Given this list of marker genes STAG2, NPR2, NONO, NXN, KAT6B, BPTF, IFT74, EIF4A3, IHH, FAM149B1, ERI1, ATP6V1B2, BRAT1, KCNJ11, BBS1, FLT4, AMMECR1, LZTFL1, YY1AP1, JAG1, RSPRY1, FANCM, VPS13B, PLXND1, KMT2A, PRDM16, MYCN, DLK1, TRRAP (NCBI Gene Id 8295), NEDD4L, ORC6, FLNB, TWIST1, MYL11, CREBBP (NCBI Gene Id 1387), CNOT3, FGF16, DLX3, ALDH1A2, HMGA2, ALG12, AKT1, LTBP1, TRIP13, BMP2, KLF13, SLC26A2, ERF, RFWD3, OBSL1, MCTP2, AGO2, ADNP, BMPR1B, RAB11B, CHRNA7, UBE3B, TMEM216, SEMA3E, ACVR1, MAD2L2, TBX4, FLII, PALB2, XRCC4, PTPN11, IFT172 (intraflagellar transport 172), TRAIP, CHSY1, H3-3B (NCBI Gene Id 3021), ATR (ATR serine/threonine kinase), ODC1, B3GLCT, AMER1, SHOX, CDKN1C, TCF20, SCAPER, MAPRE2, DHPS, EIF4A2, WNT5A, COG5, DVL1, ZFPM2, SHANK3, MACROH2A1, RBBP8, COL11A1, XYLT1, TWIST2, EVC, GJA8, DVL3, STAG1, FANCI, COG8, ATRX, RUNX2, HDAC8, PUF60, LEMD3, L1CAM, UBE3A, RAD51, CANT1, SNRPB, SPOP, CSGALNACT1, BUD23, POLA1, NCF1, REV3L, GABRD, WDPCP, POLR1A, SPECC1L, NSUN2 (NOP2/Sun RNA methyltransferase 2), GABBR1, PNPLA6, WDR4, RNF216 (NCBI Gene Id 54476), TMEM147, CDC45, RPL10, CITED2 (Cbp/p300 interacting transactivator with Glu/Asp rich carboxy-terminal domain 2), DNAJC30 (NCBI Gene Id 84277), SOS1, METTL27, BRCA2, FOXP2, SOX6, BBS7, TRIM32, STX1A, GJA1 (NCBI Gene Id 7953), WIPI2, TRAPPC9, RFC2, DDX59, TGDS, EFNB1, SLC2A10, USP7, SIAH1, GTF2IRD2, ADAMTS15, TPR (NCBI Gene Id 7175), PDPN, PITX1, IGF2, GMNN (NCBI Gene Id 51053), SH3PXD2B, BRD4, GATA4, MAF, BRAF, TBX1, HNRNPR, SMARCA2, SMC3, H19, RERE, ERCC4, RB1, ABCC8, RAF1, IFT52, IGF1, HDAC4, UBE4B, RASA2, CDH11, SDCCAG8, XRCC2, LIMK1, UBA2, HEATR3, CUL7, DEAF1, PIGL, MEG3, SALL1, TFAP2B, FANCC, GPC3, FZD2, TBX15, CKAP2L, HSPG2, GATA5, TBX5, CCNK, HOXA11, CHD6, PIGS, PRKCZ, SATB2, GTF2I (general transcription factor IIi), OGT, DNA2, ZC4H2, TTC8, ORC1, BBS12, BBIP1, HOXD13, ARID1B, PHIP, CCDC32, SOX4, GDF1, WDR26, KIFBP, ATRIP, JUP, PIGN, RTL1, BAZ1B, PTH1R, PLAG1, HIC1, BBS9, SIN3A, LMX1B, FANCA, FGD1, BBS5, KRAS, KDM1A, PLK4, CCDC47, QRICH1, TRPM3, NUP85, MECOM, MIA3, TMEM231, KMT2B, PCNT, CHD8, NSD2, SPEN, LUZP1, BRF1 (BRF1 RNA polymerase III transcription initiation factor subunit), GJA5, KDM6B, KDM4B, ATG7, AHDC1, CCDC8, FANCF, IFT140, MRAS, MAP1B (NCBI Gene Id 4131), IFT27, SMOC1, TOPORS, BHLHA9, TCTN3, NKX2-5, MAPK1, DPF2, MAPK8IP3, BBS10, LIG4, CEP57, CBL, FANCD2, DACT1, ORC4, NPHP1, TRIO, NEXMIF, EP300, RBM8A, RAI1, KAT8, EHMT1, SMAD4, NARS2, ELN, MASP1, GATA6, CUL4B, HNRNPH1, FKBP6, TRPS1, GDF5 (growth differentiation factor 5), MKS1, TAF4, PDE6D, SCLT1, TMEM270, CSNK2A1, BUB1B, FGFR3, HOXA13, CEP290, RRAS, PIGH, PIEZO2, BUB3, ZMYM2, EIF4H, CDT1, AUTS2, BRIP1, KDR, CDC6 (NCBI Gene Id 990), VPS37D, MEGF8, PRR12, KCNJ2, DPAGT1, ROR2, ARL6, FRA10AC1, UBR1 (ubiquitin protein ligase E3 component n-recognin 1), CEP152, KMT2D, CASZ1, DSP, OFD1, PACS2, EBF3, GNB2 (NCBI Gene Id 96628), NAA10, ALX1, HNRNPK, NKX2-6, DYM, KCNAB2, NRAS, CHD7, NEK1, TCF4, TBL2, RAD51C, MED12, H4C3, RAD21, KDM6A, GPC4, IFT122, IRX5, BUB1, RIT1, CNOT2, BMP4, TRPV4, PRKACB, RNU4-2, BBS4, NOG, BLM, ZNF462, PKDCC, KIF7, ABL1, KCNK4, MLXIPL, CAPRIN1, MAN1B1, DONSON, PIGY, ZNF292, KNSTRN, MECP2, UBE2T, IQSEC2, GRB10, CRKL, WDR35, SLX4, CCNQ, EVC2 (EvC ciliary complex subunit 2), PACS1, LMNB2, KCTD1, SIK3, LMNA, CPLANE1, SKI, PIK3CD, CTCF, CLCN3, PAICS, BCR, TAF6, SMC1A, CEP55, WDR19, PAFAH1B1, COL27A1, GTF2IRD1, SNRPN (small nuclear ribonucleoprotein polypeptide N), TFAP2A, FANCB, ATP2B1, MBD5, NUP37, ESCO2, WDR11, BRCA1, PHF21A, IFT43, NIN, RRAS2, MKKS, FGFR2, EPB41L1, SOS2, NFIX, BCOR, TELO2, RAB23, ANKRD11, KIAA0753, CENPE, EMG1, BBS2 (NCBI Gene Id 583), KDM5A, SPRED1, AFF2, NAA20, ALX3, FANCE, CFAP418, EXT2, YWHAE, DDX11, TBC1D24, PPP2R1A, RAB18, MMP23B, AP1G1, CCDC22, TP63, KPTN, CEP19, FANCL, PQBP1, LZTR1, SLC9A7, MAP3K7, FANCG, RNU4ATAC, SRCAP, MITF, NIPBL, CD96, SPRED2, MEF2C, CLIP2, here is a description of the gene set: Human Gene Set: HP_FINGER_CLINODACTYLY species: Homo sapiens Finger clinodactyly